Given this list of marker genes APEX1, APOBEC1, APOBEC3F, EGR1, OGG1, ZMPSTE24, AICDA, APOBEC2, APOBEC3C, TET2, APOBEC3A, TET1, TET3, here is a description of the gene set: species: Homo sapiens An epigenetic gene regulation mechanism that positively regulates gene expression by demethylation of cytosine residues in chromosomal CpG islands. CpG islands are genomic regions that contain a high frequency of the CG dinucleotide and are often associated with the transcription start site of genes. Human Gene Set: GOBP_POSITIVE_REGULATION_OF_GENE_EXPRESSION_VIA_CHROMOSOMAL_CPG_ISLAND_DEMETHYLATION